Given this list of marker genes NOLC1, PTTG1, TAF6 (TATA-box binding protein associated factor 6), CSTF3, RAD21, CDC25A, PHB2, CELF2, POLR2K, RO60, CHERP, KIF22, DR1, E2F3, CDC25B, CUL2, SMARCA5, CCNG2, POLR2J, KIF2C, CDK1, KHDRBS1, GTF2A2, HNRNPU, MAD2L1, CCNB2, FGFR1, CCNE1 (NCBI Gene Id 898), CDC7, IGF2BP3, NFKBIB, KNTC1, SNAPC5, KPNA2, RBM4, TBP, GTF2E2, PABPC4, CDK3, CCNG1, UBE2C, TFAM, RRP9, CDKN1C, CCNB1, HNRNPL, PPP5C (protein phosphatase 5 catalytic subunit), ZW10, HNRNPF, HNRNPUL1, DUSP4, TBRG4, NCAPD2, NDC80, KIF23, POLR2I, CXCR4, ACTL6A, CDK2, BUB3, CCNA1, RBM3, MAZ (MYC associated zinc finger protein), TCEA1, SSB, DUSP6, DCTN2, NEK4, RCC1, CDK6, CDK4, E2F1, HNRNPDL, DUSP2, TAF1A, ELL, RBM6 (NCBI Gene Id 646559), CORO1A, GFI1, CDK2AP1, PLK1, BUB1, POLR2D, CDK7, HNRNPA2B1, CCNA2, WEE1 (WEE1 G2 checkpoint kinase), EMG1, DDX11, THOC1, GTF2F2, SMC2, MAD1L1, SMARCC1, BIRC5, CUL4A, here is a description of the gene set: studied in species Homo sapiens Transcription. Human Gene Set: MODULE_124